Given this list of marker genes ENSG00000283544, OR5AC2, ENSG00000296251, CPOX, OR5H2, OR5H15, RCC2P5, OR5H1, RNU6-488P, EPHA6, ENSG00000289509, WDR82P1, OR5H5P, OR5H14, OR5AC1, GPR15, OR5BM1P, CRYBG3, RIOX2, ARMC10P1, GABRR3, DHFR2, OR5H6, NSUN3, CDV3P1, PROS1, OR5H8, ARL13B, OR5AC4P, ARL6, RPL38P4, TPTE2P7, RBBP4P2, LINC00879, RPL18AP8, OR5K4, HNRNPKP4, MTHFD2P1, OR5K2, HMGN1P7, CLDND1 (claudin domain containing 1), RNU6-511P, OR5H4P (olfactory receptor family 5 subfamily H member 4 pseudogene), OR5K3, POU5F1P7, RNU6-1094P, UBFD1P1, STX19, OR5K1, ENSG00000286447, OR5H7P, OR5H3P, RBBP4P7, RPS18P6, MIR8060, here is a description of the gene set: studied in species Homo sapiens Human Gene Set: chr3q11